The following is a description of a gene set: studied in species Homo sapiens A protein complex that possesses DNA polymerase activity and is involved in template directed synthesis of DNA. Human Gene Set: GOCC_DNA_POLYMERASE_COMPLEX, and this is the list of marker genes: MCM3, PRIM1, POLD2, CRCP, POLD1, POLD4, POLE, CHRAC1, POLE4, DNA2, POLA2, POLE3, POLG2, PRIM2, POLG, MAD2L2, POLD3, REV3L, POLA1, POLE2